Given this list of marker genes POU3F4, CPEB4, PDZRN4, TSPAN8, NCDN, TFDP2, FOXG1, CRCT1 (cysteine rich C-terminal 1), NDP, PLAG1, DMD, TOB1, TFAP4, OSBPL6, SPRR4, ZNF366, HOXA4, GTF2A1, NMNAT2, VGLL3, CTNNAL1, AP1G2, FOXP2, TBX4, MLLT6, AFF3, IL5, UTY, NFIX, PLA1A, TENM1, CDC42EP3, ZFPM2 (zinc finger protein, FOG family member 2), KLF12, ENPEP (NCBI Gene Id 2028), IBSP, RFTN2, NFIB, RTL9, TENM3-AS1, ID1, CYB561D1, PTGR3, NKD1, IER3, PDCD4, TWIST2, NFATC4, ELMO3, RUNX1T1, CLIP2, LHX5, MITF, ZEB2, DUSP1, UBALD1, HOXA7, IMP3, KDM6A, NEUROD2, PATL1 (NCBI Gene Id 219988), OTX2, MED12, EPHB1, PPARGC1A, TBL1X, CHCHD7, GIPC2, SULF2, CNTLN, NECTIN1, ZBTB22, SERPIND1, CYP26B1, VAX1, SLC25A51, IL25, BUB1, PNMA1, FOXN3, TTR, DCDC1 (NCBI Gene Id 57629), ASIC5, CALD1, NSG2, JPT2, KCNK18, MRPS18B, SCUBE3, DRD3, PIK3C2A, DNAJA4, MOSMO, FLOT1, OLIG3, ZHX2, TSHZ3, CCN1, PPP1CB, FGF13, KLHL1, FEZF2, ADGRB3, PHEX, F11, OPRM1, ANGPTL1, UBXN10, LMO4, INHBA, FOXB1, PPP1R10, THOC5, TLE4, HOXA11 (NCBI Gene Id 3207), PRMT6, NR6A1 (nuclear receptor subfamily 6 group A member 1), SKIDA1, DCHS2, PCDH9, ZBTB37, CHN2, CELF4, LINC03122, TNMD, GABRA1, ORC4, ARTN, IKZF2, ARHGAP30, CPNE1, ANXA1, TYRO3, CDK6, WNT4, COL13A1, ID2, SLC44A1, GPRIN3, SOX14, SLC6A4, IFNA17, KLF3-AS1, PHF21A, ITPKB, KRTAP11-1, TNF, CITED2, TAC1, RORA, KCTD15, SPMIP6, HSP90B1, DNAJB7, RASSF6, SP8, FOXN1, PLCB1, SLC16A6, GPM6A, DAAM1, MAB21L3, BAZ2B, LINC00314, IL21, ATP1B4, BAIAP2, FRMD4A, RUNX2, FUT8 (fucosyltransferase 8), ANKRD39, RIMKLA, RAB6C, KLF3, LCP2, LPP, ABT1, PRDM1, LMO3, LBX1, ZMAT4, RBP4, RAB3IP, FAM27E5, BCL11B, SIN3A, ZNF521, NEDD4, PRR34, FAM20A (NCBI Gene Id 54757), ANKRD28, GFRA1, LTA, B3GALT2, EGR2, SOX2, ABL2, ATP2A3, SCARF2, CYP2J2, TBX2, ITGA8, CDAN1, ERRFI1, KCP, SSH3, RNF17, BAMBI, LINC01138, ONECUT2, CACNA1H, SLITRK6, GAL3ST4, ISG20, HAS2, FOXA2, NOC3L, NSD3, HESX1, ZNF827, HOXC4 (homeobox C4), PELI2, RARG, here is a description of the gene set: Genes having at least one occurrence of the motif KGNANTRTTTRYTTW in the regions spanning 4 kb centered on their transcription starting sites. This matches the FOXA2 transcription factor binding site V$HNF3B_01 (v7.4 TRANSFAC). species: Homo sapiens Human Gene Set: HNF3B_01